The following is a description of a gene set: Genes down-regulated in HEK293T cells overexpressing FLAG-NRF3 from publication Ibrahim L, Mesgarzadeh J, Xu I, Powers ET, Wiseman RL, Bollong MJ (PMID 33096892) Human Gene Set: IBRAHIM_NRF3_DOWN The NRF transcription factors NRF1, NRF2, and NRF3, are a subset of Cap'n'collar transcriptional regulators which modulate the expression of genes harboring antioxidant-response element (ARE) sequences within their genomic loci. Despite the emerging physiological importance of NRF family members, the repertoire of their genetic targets remains incompletely defined. Here we use RNA-sequencing-based transcriptional profiling and quantitative proteomics to delineate the overlapping and differential genetic programs effected by the three NRF transcription factors. Comparing our data to recent profiling analyses, we create consensus target gene sets regulated by NRF1, NRF2, and NRF3, genetic programs which we determine to be differentially regulated in human tissues. Together, our data provide a quantitative assessment of how NRF family members sculpt proteomes and transcriptomes, essential information for future studies evaluating the role of NRF factors in normal physiology and disease. species: Homo sapiens, and this is the list of marker genes: CITED2, PMM1, ARHGAP23, PLAT, DBNDD2, DLG4, IER2, CCNJL, H1-0, CDKN1A, SMAP1, SEMA4C, NOG, HECTD3, TAF1D